The following is a description of a gene set: Deadenylation-dependent mRNA decay Human Gene Set: REACTOME_DEADENYLATION_DEPENDENT_MRNA_DECAY studied in species Homo sapiens, and this is the list of marker genes: XRN1 (NCBI Gene Id 54464), EIF4E, TUT7, DIS3, CNOT2, LSM6, CNOT7, EXOSC9, LSM2, CNOT1, EXOSC3, CNOT10, LSM3, CNOT3, EXOSC5, DCP1A, DCPS, PATL1, EXOSC8, EXOSC1, CNOT11, SKIC2, PARN, EIF4B, LSM1, CNOT6, DCP1B, EIF4G1, LSM7, CNOT4, CNOT8, EXOSC2 (exosome component 2), EIF4A2, SKIC3, CNOT6L, NT5C3B, PAN2, TUT4, EDC4 (NCBI Gene Id 23644), PABPC1, PAIP1, EIF4A1, HBS1L, SKIC8, EXOSC6, DCP2, LSM4, EXOSC7, EXOSC4, LSM5, EDC3, EIF4A3, PAN3 (poly(A) specific ribonuclease subunit PAN3), TNKS1BP1, DDX6, CNOT9